Given this list of marker genes LMNA, SMN2, SPG11, LMX1B, SYNE2 (NCBI Gene Id 26075), RYR1, VMA21, ADSS1, HNRNPDL, SPTLC1, REEP1, TRPV4, DYNC1H1, TMEM43, EMD, FHL1, NEFL, SMN1, SYNE1, SGCD, ANO5, here is a description of the gene set: Abnormality thigh musculature morphology studied in species Homo sapiens Human Gene Set: HP_ABNORMALITY_THIGH_MUSCULATURE_MORPHOLOGY